Given this list of marker genes Eny2, Taf2, Kat14, Trrap, Usp22, Supt3, Kat2a, Pole3, Wdr5, Taf5, Map3k7, Pole4, Tada3, Tada2b, Tada2a, Taf5l, Supt20, Taf6, Tada1, Supt7l, Taf6l (NCBI Gene Id 75618), Sf3b3, Taf12, Atxn7l3, Dr1, Sf3b5, Taf9b, Zzz3, Kat2b, Taf7, Taf4, Yeats2, Taf9, Mbip, Sgf29, Atxn7, Taf10, here is a description of the gene set: Mouse Gene Set: GOCC_SAGA_TYPE_COMPLEX species: Mus musculus A histone acetyltransferase complex that acetylates nucleosomal histones H2B, H3, or H4 and is required for the expression of a subset of Pol II-transcribed genes. This complex includes the acetyltransferases GCN5/KAT2A or PCAF/KAT2B, several proteins of the ADA, SGF and SPT families, and several TBP-associate proteins (TAFs).